The following is a description of a gene set: Any process that results in a change in state or activity of a cell or an organism (in terms of movement, secretion, enzyme production, gene expression, etc.) as a result of a cisplatin stimulus. studied in species Mus musculus Mouse Gene Set: GOBP_RESPONSE_TO_CISPLATIN, and this is the list of marker genes: Ddx11, Slc31a1, Bok, Hmox1, Nfkbiz, Abcc2, Rad51, Timeless